Given this list of marker genes ALK, HACE1, MYCN, KIF1B, LIN28B, PHOX2B, LMO1, GNB2, here is a description of the gene set: Horner syndrome Human Gene Set: HP_HORNER_SYNDROME An abnormality resulting from a lesion of the sympathetic nervous system characterized by a combination of unilateral ptosis, miosis, and often ipsilateral hypohidrosis and conjunctival injection. species: Homo sapiens